The following is a description of a gene set: studied in species Homo sapiens Regulated proteolysis of p75NTR Human Gene Set: REACTOME_REGULATED_PROTEOLYSIS_OF_P75NTR, and this is the list of marker genes: APH1A, PSENEN, NFKB1, PSEN1, NCSTN, NGFR, RELA, APH1B, ADAM17, PSEN2, TRAF6